The following is a description of a gene set: studied in species Mus musculus Mouse Gene Set: GOBP_POSITIVE_REGULATION_OF_DNA_BINDING Any process that increases the frequency, rate or extent of DNA binding. DNA binding is any process in which a gene product interacts selectively with DNA (deoxyribonucleic acid)., and this is the list of marker genes: Hmgb2, Igf1, Hand2, Calm1, Hes1 (NCBI Gene Id 15205), Ercc2, Sirt2, Pax6, Traf6, Brd4, Pou4f1, Pitx2, Hipk1, Prkn, Isl1, Ngf, Plaur, Lamtor5, Trim28, Irf4, Nme1, Ski, Mmp9, Ddrgk1, Hipk3, Ifng, Myocd, Pou4f2, Txn1, Pinx1, Dazap2, Trim6, Foxc1, H1f0, Hmgb1, Twist1, Niban2, Hipk2, Egf, Smarca4, Gata3 (GATA binding protein 3), Edf1, Rb1, Neurod1, Park7